Given this list of marker genes NUF2, CAMP, LTF, CDK1, LGALS3BP, SEPTIN7, NRM, ACSL5, H4C4, VPS4A, CALM1, HNRNPA3, RAD51, API5, CENPS, H4C6, TRPC4AP, PSMD8, CCS, EML3, TRIP13, SASH3, MAD2L1, HNRNPU, SLC35A5, CENPH, KPNA2, CD2BP2, H4C16, STMN1, MCM6, H1-5, SUOX, DAZAP2, RAE1, CBX5, VPS26A, RAB5C, RAD52, NCAPG, TACC3, NEIL3, CSK, GMPPA, TPX2, PIGQ, TIMM17B, TPI1, CDCA8, CYBA, CHAF1B, ERP29, NECAP2, DLGAP5, SMAP2, H4C14, PPP4C, CHEK1, PRC1, HDAC1, PCBP1, LIMK2, SAP30BP, CDC42, SPC25, TACC1, LCN2, CD81, NPC2, PGLYRP1, SLPI, H2AC15, HSPD1, IGHG3, BIRC5, PTMS, SPC24, TTC9C, EDEM2, JAKMIP1, SLC31A1, SSR1, KIF14, PLAC8, CCNA2, MBNL3, CENPA, CKS1B, COPE, PPP1R8, GUSB, TRAM2, TTK, BRCA1, GET3, CDC45, H3-3A, RAB27A, ERH, KLC1 (kinesin light chain 1), HSP90B1, PMM1, LIG1, RAB5B, PPP1CA, PDIA3, GGTA1, TNFRSF17, SP100, COX5B, KIF22, RPN1, LMAN2L, NCAPG2, NRAS, NUDT1, PRG2, UBE2S, HCLS1, SEPHS1, AK2, LAG3, PRRC1, EHD4, COX7A2, BAX, SCARNA17, TENT4A, GLCCI1, DERA, RNF5, PFDN2, FKBP8, CLSPN, TRIM25, PLK1, POLE, S1PR4, H2AC4, SFT2D2, DNAJC9, TOP2A, POLA1 (NCBI Gene Id 5422), INCENP, DERL3, RAC2, ECT2, H2AC25, JCHAIN, KIF4A, H2AZ1, ANP32E, PRDX3, RPA1, FKBP2, SLC25A33, ARHGAP11A, CORO1A, GAS7, KIF11, ENDOU, UQCRQ, HNRNPR, AHSA1, EPHX1 (epoxide hydrolase 1), here is a description of the gene set: Genes up-regulated in B lymphocytes with ZFX knockout: control versus stimulated by anti-IgM for 2h. from publication Arenzana TL, Smith-Raska MR, Reizis B (PMID 19329779) The development, homeostasis and function of B lymphocytes involve multiple rounds of B cell receptor (BCR)-controlled proliferation and prolonged maintenance. We analyzed the role of transcription factor Zfx, a recently identified regulator of stem cell maintenance, in B cell development and homeostasis. Conditional Zfx deletion in the bone marrow blocked B cell development at the pre-BCR selection checkpoint. Zfx deficiency in peripheral B cells caused impaired generation of the B-1 cell lineage, accelerated B cell turnover, depletion of mature recirculating cells, and delayed T-dependent antibody responses. Zfx-deficient B cells showed normal proximal BCR signaling, but impaired BCR-induced proliferation and survival. This was accompanied by aberrantly enhanced and prolonged integrated stress response, and delayed induction of Cyclin D2 and Bcl-xL proteins. Thus, Zfx restrains the stress response and couples antigen receptor signaling to B cell expansion and maintenance during development and peripheral homeostasis. species: Homo sapiens Human Gene Set: GSE13547_CTRL_VS_ANTI_IGM_STIM_ZFX_KO_BCELL_2H_UP